Given this list of marker genes KRT5, KRT14, KRT1 (keratin 1), ATP2A2, COL14A1, ENPP1, AAGAB, GJB6, GJB2, LRP1, PSENEN, POGLUT1, POFUT1, COL7A1, here is a description of the gene set: studied in species Homo sapiens Human Gene Set: HP_HYPERKERATOTIC_PAPULE A circumscribed, solid elevation of skin with no visible fluid, varying in size from a pinhead to less than 10mm in diameter at the widest point that is composed of localized hyperkeratosis (the latter may be demonstrated histopathologically). Hyperkeratotic papule